Given this list of marker genes TRIM36, WAC, COL24A1, PJA2 (NCBI Gene Id 9867), TTC39B, SLC25A1, GNL1, PTGDR, CYLD, TNFSF4, ADGRE1, AFF1, CAPS2 (NCBI Gene Id 84698), PIKFYVE, MPZ, MDM2, SYN2 (synapsin II), ANGPT1, CBX4, SENP7, CCL24, AQP9, CCDC25, CAMLG (calcium modulating ligand), OLR1, PRPF4, SIRT6, ALPK1, MYO10, SP110, TAOK1, AOC3, RHOG (NCBI Gene Id 391), CTSC, ATF2, ACBD3, DUBR, AMBRA1, ZSCAN25, LCAT, LRRC3, MSL2, PLCL2, RARRES1, SUDS3, TBC1D10B, TSPAN3, ARFGEF1, FAM114A1, BCL9, IL1RAP, CTXN1, RRAD, VPS37A, M6PR, ZHX2, BCHE, TRAM2, VOPP1, TRMT1L, MFAP5, ATP11A, SLC25A38, CCDC30, EZR, IL10RA, ACSL5, SSR3, FAM43A, PIAS1, USO1, OTUD5, RNASE10, IL36A, RGS3 (regulator of G protein signaling 3), ST6GAL2, GPR27, CDKN2B, RNF139, FIGN, OAF, APPBP2, SLC4A3, TMEM38B, FCN1, MAP4K3, AGTRAP, SLC30A6, UBXN4, CA2, DNAJC1, PLTP, KRT73, CTH, DMTN, CEPT1, NHLRC2, GNG12, SPSB1, GDPD1, SF3B1, CH25H, ARMC7, CAPNS2, FLRT2, MED29, ATXN2, SIPA1L1, SH3BP4, KIF12, PSEN1, LAP3, FGR, TTLL10, WHAMM, ARMH4, VASH1, ITPR1, ITPRIP, MOB1A, TMIGD1, SWAP70, RBL1, ZDBF2, TMEM219, APAF1, MTMR11, TPR, GTF2F1, C1QTNF1, TAPBP, NPY5R, ORC4, CUL1, SH3BP2, ZNF467, DOCK10, ZBTB5, KMO, NFIX, CCIN, RASGRP1 (NCBI Gene Id 10125), IFITM2, SPEN, RAB20, KMT2C, CYP26A1, ETF1, ETV2, TMEM248, KMT2D, ANKRD33, SSH3, CASP7, LRRC41, ARG2, DEDD, ZNF654 (NCBI Gene Id 84158), HDAC9, DPEP3, SEC23B, GFPT1, CREB3, SLPI, ZNF217, POLR3C, SETD1B, EHBP1L1, SCN5A, EPS15L1, SLC16A10, CDK12, PAK2, CTU1, ACAA1, MT1E, CABLES2 (NCBI Gene Id 91264), POLDIP3, GNA13, TMEM67, DUS2, WBP4, ORAI2, ARFGAP1, ASS1, APCDD1, CCNB1IP1, HIVEP3, STIM2, HIVEP2, SDAD1, LPCAT2, IL2RA, AKAP13, USP53, ADAMTS4, DAZ2, PDSS1, LCK, DDHD1, here is a description of the gene set: Human Gene Set: GSE14769_UNSTIM_VS_360MIN_LPS_BMDM_DN Genes down-regulated in comparison of unstimulated macrophage cells versus macrophage cells stimulated with LPS (TLR4 agonist) for 360 min. species: Homo sapiens The innate immune system is a two-edged sword; it is absolutely required for host defense against infection, but if left uncontrolled can trigger a plethora of inflammatory diseases. Here we used systems biology approaches to predict and validate a gene regulatory network involving a dynamic interplay between the transcription factors NF-κB, C/EBPδ, and ATF3 that controls inflammatory responses. We mathematically modeled transcriptional regulation of Il6 and Cebpd genes and experimentally validated the prediction that the combination of an initiator (NF-κB), an amplifier (C/EBPδ) and an attenuator (ATF3) forms a regulatory circuit that discriminates between transient and persistent Toll-like receptor 4-induced signals. Our results suggest a mechanism that enables the innate immune system to detect the duration of infection and to respond appropriately. from publication Litvak V, Ramsey SA, Rust AG, Zak DE, Kennedy KA, Lampano AE, Nykter M, Shmulevich I, Aderem A (PMID 19270711)